The following is a description of a gene set: studied in species Homo sapiens Human Gene Set: GOMF_IRON_ION_BINDING Binding to an iron (Fe) ion., and this is the list of marker genes: DNAJC24, P3H2, FTH1, OGFOD1, TPH2, PLOD1, CYP46A1, FTO, CYP2J2, CYP27A1, ALKBH2, MELTF, P4HA2, ALKBH1, CYP4Z1 (NCBI Gene Id 199974), PHF2 (PHD finger protein 2), ALOX12B, ACO2, PAH, CYP17A1, EGLN2, TET2, CYP2A7, CYP4Z2P, CYP2B6, CYP1B1, CYP8B1, CYP3A7, OGFOD2, CYP4F3, SNCA, CYP4V2, ADO, CYP7B1, P4HA1, CYP1A1, CIAPIN1, CYP4F11, ALKBH3, CYP11A1, TPH1, FTHL17, HBA1, P3H3, SC5D, JMJD6, PPP1CA, CYP2A6, CYP2S1, CYP27B1, CYP39A1, FA2H, HAAO, CYP51A1, CYP20A1, NFU1, CYP2C19, CYP2C9, CYP19A1, EGLN1, MSMO1, KDM7A, LCN2, ALKBH8, CYP4F22, ALOX5, CYP4F12, ALOXE3, CYP3A43, CYP26A1, CYP4X1, XDH, TH, TYW5, CYP4F2, PPEF2, ALOX12 (NCBI Gene Id 239), CALR, CYP4F8, PTGIS, CYP26B1, CYP4B1, TBXAS1, PLOD2 (procollagen-lysine,2-oxoglutarate 5-dioxygenase 2), DPH3, CYP11B2, CYGB, CYP1A2, OGFOD3, CYP7A1, CYP2C8 (NCBI Gene Id 1558), HBQ1, FAXDC2, FTH1P19, CYP27C1, FTMT, CYP4A22, CYP2G1P, TET1, AOX1, BBOX1, PLOD3, CH25H, SCD, PPEF1 (protein phosphatase with EF-hand domain 1), ACP5, P4HA3, ISCA2, ABCE1, CYP2U1, KDM3A, DOHH, TMLHE, HIF1AN, CYP11B1, HBZ, PHF8, LTF, ALOX15B, CYP2E1 (cytochrome P450 family 2 subfamily E member 1), FTL, RIOX1, ETHE1, SCD5, ALOX15, FBXL5, CYP3A5 (NCBI Gene Id 1577), ADI1, CDO1, CYP2W1, MIOX, ISCU, PHYH, TF (transferrin), HBA2, EGLN3, P4HTM, RRM2, CYP4A11, P3H1, CYP2D6, CYP2R1, CYP26C1, FDX1, FXN, CYP3A4, CYP24A1, AGMO, FECH, CYP2C18, CYP21A2, CYP2A13, CYP2F1